The following is a description of a gene set: This event has been computationally inferred from an event that has been demonstrated in another species.<p>The inference is based on the homology mapping from PANTHER. Briefly, reactions for which all involved PhysicalEntities (in input, output and catalyst) have a mapped orthologue/paralogue (for complexes at least 75% of components must have a mapping) are inferred to the other species. part of: Cilium Assembly electronically inferred by orthology from the curated human pathway species: Mus musculus Reactome Pathway: Assembly of the 9+0 primary cilium, and this is the list of marker genes: Dynlrb2, Nphp1, Atat1, Tubal3, C2cd3, Cct2, Cep72, Tuba1a, Cnga4, Rab3ip, Wdr35, Dync2i1, Tctn2, Sstr3, Tubb4b, Tuba8, Clasp1, Ift70b, Tuba3b, Sfi1, Cdk1, Cep41, Plk1, Cep290, Dynlt2a3, Tubb2b, Haus7, Ift22, Haus5, Lztfl1 (NCBI Gene Id 93730), Prkar2b, Smo, Dynlt5, Dync2i2, Prkaca, B9d2, Kifap3, Cenpj, Exoc1, Rab11a, Ttc21b, Ift172 (intraflagellar transport 172), Ift88, Arl3, Nedd1, Nphp3, Cngb1, Bbs1, Cep89, Ift81, Nde1, Cct3, Cep192, Dctn1, Cep57, Tuba1b, Csnk1e, Bbs10, Mks1, Bbs2, Cep83, Tuba1c (NCBI Gene Id 22146), Ift80, Tubb6, Dynlt2a2, Cep63, Ninl, Rab8a, Actr1a, Exoc2, Ift27, Cct5, Cep152, Ift57, Haus8, Mchr1, Tubb4a, Haus1, Exoc7, Tuba4a, Cep131, Ift74, Tctn3, Ttc8, Ift25, Dynll1, Ywhae, Kif3c, Inpp5e, Cct8, Bbs7, Asap1, Cep43, Ift70a1, B9d1, Rp2, Rho, Cluap1, Cep135, Sdccag8